Given this list of marker genes Ngf, Ngfr, Mag, Omg, Lingo1, Rtn4, here is a description of the gene set: electronically inferred by orthology from the curated human pathway Reactome Pathway: p75NTR regulates axonogenesis This event has been computationally inferred from an event that has been demonstrated in another species.<p>The inference is based on the homology mapping from PANTHER. Briefly, reactions for which all involved PhysicalEntities (in input, output and catalyst) have a mapped orthologue/paralogue (for complexes at least 75% of components must have a mapping) are inferred to the other species. part of: p75 NTR receptor-mediated signalling species: Mus musculus